The following is a description of a gene set: Any process that results in a change in state or activity of a cell or an organism (in terms of movement, secretion, enzyme production, gene expression, etc.) as a result of an L-glutamate stimulus. studied in species Homo sapiens Human Gene Set: GOBP_RESPONSE_TO_L_GLUTAMATE, and this is the list of marker genes: AIFM1, FYN, HCN1, GRIN2D, BCL11A, PCNA, HPCA, GHSR, AMIGO1, KCNB1, PRKN, TUBA1A, ABCB1, GRIA1, TNF, CREB1, UFL1, BAIAP2 (BAR/IMD domain containing adaptor protein 2), TMBIM6